Given this list of marker genes MPV17, IDH1, TUBB, MAPRE2, ACTB, HOXD13, PTEN, AKT1, H19, EBP, AGGF1, PTH1R, PTHLH, IDH2, PIK3CA, IGF2, PORCN, here is a description of the gene set: species: Homo sapiens Difference in length or size between the right and left arm. Human Gene Set: HP_UPPER_LIMB_ASYMMETRY Upper limb asymmetry